The following is a description of a gene set: Genes predicted to be targets of miRBase v22 microRNA hsa-miR-1297 in miRDB v6.0 with MirTarget v4 prediction scores > 80 (high confidence targets). Human Gene Set: MIR1297 from publication Chen Y, Wang X (PMID 31504780) studied in species Homo sapiens, and this is the list of marker genes: MICAL3, BLOC1S2 (biogenesis of lysosomal organelles complex 1 subunit 2), CCDC82, CDH11, NSD2, UGT8, ZNF148, CTTNBP2NL, BCR, CTSV, WDR33, EDRF1, HOXA9, SULF1, MMP16, GRB10 (NCBI Gene Id 9769), ART3, NAP1L5, POM121, NCOA4, CHSY1, ADAMTS17, DBF4B, CXADR, SF3A1, RB1, USP3, SYT10, TMEM106B, RBM20, MTDH, KIAA1549L, EIF4G2, REPS2, USP25 (NCBI Gene Id 29963), ZIC5 (Zic family member 5), GOLGA3, THAP2, TMCC1, IPO7, REEP3, RESF1, JAG1, PHF20L1, CREBBP, CDH4, SCN9A, RNF6, ACVR1C, DNAL1, CDC37L1, TET2, WNK3, SEMA6D, RSPRY1, CARF, MDN1, RGS4, ULK2, UBR3, EP300, SLC33A1, NAA15, RHOU, FBXL19, SSX2IP, AKAP7, PFKFB2, CREB1, ARMCX2, HOOK3, BEND4 (NCBI Gene Id 389206), KPNA2, C2CD5 (NCBI Gene Id 9847), PLCB1, EZH2, SLC2A3, MYH10, RBM24, ADAM17, PELI2, CXXC4, PPP1R3D, UCK2, MAP3K7, USP9X, SKP2, PLP1, B3GNT5, TTPA, ZNF608, VANGL2, SLC36A4, RAB21, IARS1, PHLDB2, ERC2, PHF3, ACSL3, CACNB2, OSBPL2, AGPAT5, PLOD2, PLEKHH1, FBXO11, MAN2A1, CAMSAP1, ZFC3H1, STK39, ZCCHC24, PURG (NCBI Gene Id 29942), DAPK1, ZDHHC6, NCEH1, ARB2A, PAG1, ABHD18, GABRB2, NAGPA, COL22A1, EPHA5, PECAM1, KLHL18, CNR1, PPP3CB, SLC19A2, ACAP2, ATM, FBXO42, CNTNAP3, DYRK1A, ZSWIM6, HOXD13, LIN28B, CASZ1, ULK1, ETNK1, FRAT2, BAZ2B, NXPE3, FGD1, DGKH, ANKRD28, GMDS, RLF, FA2H, METAP2, GPALPP1, MTM1, DFFB, STYX, ZDHHC20, TNPO1, MAT2A, WNK1, NAMPT, CAMSAP2, NATD1, COL10A1, KIAA2013, BOD1, ABHD5, SH3PXD2A, GSK3B, BOD1L2 (NCBI Gene Id 284257), OVOL2, CPED1, STRADB, BAK1 (BCL2 antagonist/killer 1), HERC2, PEX13, CNOT4, FPGT, PHF6, NAB1, PPP1R15B, PARPBP, ATXN7, EXOC8, CEMIP2, ZNF235, DMXL1, NUS1, OTUD4, TRIM65, NUP50, LOXL2, MSMO1, RPGR, PITPNC1, ATF2, SLC4A4 (NCBI Gene Id 8716), VPS13C, ZBTB18, ARHGAP21, MATR3, YTHDF3, MFHAS1, SEPTIN10, PGRMC2, MARK1 (NCBI Gene Id 55887), ATP11C, ANKS1A, CELSR1, DDX17, SOWAHC, CBLL1, LEF1, SLC25A20, ZNF598, TRANK1, BID, RASSF3, GMNC, PCDH18, TWF1, PDE7A, EPC2, ICE1, VDAC1, ARPP19, PGM2, MCL1, BCL7B, CEBPG, NEK6, CTNND2, SUZ12, PFKFB3, CDK6, EYA3, RCN2, REEP4, ZNF430, FAM98A, TTC13, PALM2AKAP2, BLTP3A, MLANA, MFSD14A, HMGA2, CARMIL1, COL1A2, ANKRD63, ZNF710 (zinc finger protein 710), RHOQ (NCBI Gene Id 56679), SLC5A1, MCUR1, ZNF462, CRADD, MAP3K9, TTC28, PRKCD, ACBD5, ABCC4, CCND2, USP53, SOCS7, UBE2G1, ZBTB20, TANC2 (NCBI Gene Id 80259), NACC2, GPR52, CHFR, KPNA6, SRP19, NIPA1, DEPDC1, RHD, DCDC2, SENP5, NEK1, E2F7, PHTF2, MIER3, ARPP21, BBX, FGF18, ALS2, ATP1A2, CNTNAP3B, DOCK4, UBE2E2, CPSF2, RFX7, KLHL42, IQCJ, TAF2, B4GALT4, SLC38A2, DCUN1D3, TTPAL, LSM11, SFPQ, USP37, NLK, MAP2, PPP2R3C, SLC25A36, MTFMT, TMEM86A, HGF, EP400, LSM2, AMOT, RAB5IF, SLC25A16, SH3D19, HOXC9, UBE2J1, ARL5B, ZNF708, ITPRID2, DNAAF6, ADGRG7, CACNA1C, EPC1 (NCBI Gene Id 80314), HOXA5, FAM136A, ARPC3, UBN2, PHF21A, TAOK1, SERBP1, BARD1, GTF2A1, MINPP1, HAS3, CLASP2, SMAD1, FAM8A1, KLF4, SRSF6, USP15, ZNF469, FAM149A, BBS7, PJA2, SLC35E4, CCNJ, LRRC74B, ADM, CTH (cystathionine gamma-lyase), EIF2S1, POLH, FKTN, ENOSF1, PDHX, RALYL, CHD1, RCBTB1, ACADM, SH3RF1, PALS2, NFE2L3, PRR5L (NCBI Gene Id 79899), WDR20, TJP2, PPP4R1, EIF5, SLC22A23, ASPN, SHANK2, G2E3, IL18R1, SSH2, TOB1, LRRC2, TMEM132C, SNN, PFDN4, UBE4B, BAG4, SV2C, RNF141, PAK2, PAN3, SYNPO2, NIPAL2, RUFY2, RYK, POM121C, ZNF12, SFXN1, SAMD8, TMEM184B, IPMK, LSM12, FHIP1A, DCLK1, UBE2K, TFAP2A, MLLT3, PPP3R1, SBNO1, PSD3, ADAM19, CEP350, INTS2, GPSM1, GNA13, ARL6IP6, CD2AP, FRZB, THAP5, EREG, FBXO28, FLVCR1, YAF2, CILP, USP6, PRKCQ, HDAC9, BFAR, DDX52, NID1, SLC2A13, FANCF, RTF1 (NCBI Gene Id 23168), RPS6KA6, GMFB, REST, SACS, CHIC1, DTD2, MAEA, CMTM4, MTX2, TMEM64, ATPAF1, LARP4B, DLG5, NPR3, ANKRD52, TP53INP1, RFX3, OSBPL11, BTBD7, SFT2D3, HMGA1, MTTP, DENND1B, BMPR1B, NT5DC1, SLC2A14, SLC16A6, CTXN3, GALNT10, SLC45A4, HOXC4, FUT9, MXI1, ANKS1B, BRWD1, CCDC6, KCTD18, PTPRD, TMEM260, COL5A1, CDK2AP1, INHBB, SLC24A4, RCOR1, TNRC6C, THUMPD3, DMRT3, ATAD1, ZDHHC18, ATAD2B, APPL2, FAM199X, RCC1L, ESR1 (estrogen receptor 1), RCN1, NHS, TMC7, STXBP5, TRIB2 (tribbles pseudokinase 2), MIER1, GRSF1, ZNF516, KAZN, EAF1, CCDC28A, ZNF664, SRCAP, PYGO1, TMEM265, EPB41L3, TNRC6A, SLC9A2, CAPZA1, CDC6, DNMT3B, FAM227A, ADAMTS6, CPPED1, ABL2, PIAS2, TRPC3, ITGA6, MRAS, PAWR, ADAM23, PEDS1, UFM1, PLEKHG1, CDK13, SNX20, SLC30A7 (solute carrier family 30 member 7), WNK2, TM2D3, EDEM3, GNPNAT1, PIM1, ZBTB44, MAP7, TBC1D4, CREBZF, ITGB8, UBA5, COL12A1, PMAIP1, PTGS2, CELF2, RIPPLY3, RBM46, TBC1D30, ARFGEF1, SELP, G3BP2, PCDH9, TOP1, SCAMP1, LARP1, CHORDC1, TMEM135, TMEM248, LMLN, ERLIN1, RFK, CBLB, HTR1B (NCBI Gene Id 3351), UBE2H, ADRA1A, FCAR, CD200, TET1, ADAMTS19, NABP1, CDH20, PRLR, COL19A1 (collagen type XIX alpha 1 chain), JARID2, SPCS3, PHF14, MKNK2, RAP2C, CHAC1, MEX3B, FRMD4B, SALL3, AKIRIN1, ARK2N, DUSP5, PCNX1, NUDT11, TNRC6B, SPDYE5, KCNJ2, MAB21L1, GABRA4, NT5C1B-RDH14, TRDMT1, PARP14, ADAM9, PHAF1, CREBRF, KCNQ4, MAPK6, CCNJL, LNX2, CDK8, ZFHX4, APCDD1 (APC down-regulated 1), PALM3, CIPC, SLC7A11, ZNRF3, TENT2, BHLHE40, HSPA8, BTG1, ZNF410, STRBP, DNA2, ALDH5A1, PIK3R3, COMMD8, LTBP1, ITGA5, LIMS1, GRHL3, PTBP3, SRGAP1, TGIF2-RAB5IF, HEPHL1, ELAVL2, ZNF236, SLC1A1, YPEL1, CPD, GBP1 (NCBI Gene Id 2633), TAF9B, PTEN, TBC1D15, ST6GAL2, RDH14, VGLL4, ZNF652, TMEM68, POLR3G, KBTBD8, TNNT1, ZNF44, TET3